Given this list of marker genes Cnot3, Actl6a, Pramel7, Tet1, Sf3b6, Zp3, Kdm4c, Mfn2, Cdh1, Prdm14 (PR domain containing 14), Hand1, Supt6, Skil, Srf, Sf3b1, Hopx, Eomes (eomesodermin), Rbm46, Txnrd3, Junb, Rrp7a, Sp3, Cdx2, Gabpa, Cnot1, Pbrm1, Cnot2, Esrrb, Rpl7l1, Ctr9, Tm4sf1, Pou5f1 (NCBI Gene Id 18999), Mfng, Ccnb1ip1, Tead4, Lats2 (large tumor suppressor 2), Bysl (NCBI Gene Id 53955), Tfap2c, Cited2, Ptpn18, Nr5a2, Cul3, Yap1, Wdr74, Lats1, Matr3 (NCBI Gene Id 69967), Furin, Tjp1, Sox2, Rtn4, Pnldc1, Nodal, Foxd3, Mxi1, Nop2, Nle1, Sp1, Hnf1b, Ada, Uspl1, Sox17, here is a description of the gene set: The initial formation of a blastocyst from a solid ball of cells known as a morula. species: Mus musculus Mouse Gene Set: GOBP_BLASTOCYST_FORMATION